The following is a description of a gene set: Binding to a manganese ion (Mn). species: Mus musculus Mouse Gene Set: GOMF_MANGANESE_ION_BINDING, and this is the list of marker genes: Mgat1 (NCBI Gene Id 17308), Galnt1, Xpnpep1, Xxylt1, Abl2, Pck1, Lap3, Ppm1b, Abo, Ppef1, Tdp2, Papola, Adprm, Ppm1a, Wrn, Ppm1k, Primpol, Dcp2, Hmgcl, Xylt2, Mre11a, Idi1-ps1, Mgat2 (mannoside acetylglucosaminyltransferase 2), Npepl1, Arg2, Large1, Mgat5b, Exd2, Pomgnt1, Cdipt, Mtpap, Prkaca, Galnt2, Arg1, Pim1, Abl1, Slc11a2, Nudt16, Pck2, Nudt8, Fam20c, Dyrk2, Mppe1, Sod2, Impa1, Me1, Nek4, Galnt3, Galnt4, Ppm1m, Pepd, Glul, Extl2, Xpnpep3, Atp2c1, Nudt3, Mpped2, Tssk3, Idi1, Fen1, B4galt7, Mgat5, Adcy10, Nudt7, Gyg1, Adcy2, B4galt1, Ppef2, Ppm1n